The following is a description of a gene set: The catabolic process that includes oxidation-reduction reactions for the generation of adenosine triphosphate (ATP) and primarily uses organic compounds as both electron donors and acceptors, without consumption of oxygen. Mouse Gene Set: GOBP_FERMENTATION species: Mus musculus, and this is the list of marker genes: Trp53, Cavin3, Tigar, Actn3, Slc25a12, Ldha, Adhfe1